The following is a description of a gene set: Any process that stops, prevents, or reduces the frequency, rate or extent of keratinocyte differentiation. species: Mus musculus Mouse Gene Set: GOBP_NEGATIVE_REGULATION_OF_KERATINOCYTE_DIFFERENTIATION, and this is the list of marker genes: Extl3, Trp63, Srsf6, Tgfb2, Ovol2, Hoxa7, Ezh2, Reg3g, Msx2, Reg3a